Given this list of marker genes DCHS1, FAT4, RAB23, SMOC1, SVBP, PORCN, FERMT1, FLNA, PIGS, PRKG2, LBR, HOXD13, TBX3 (NCBI Gene Id 91834), FBXL3, SHOX, EIF4A3, MEGF8, PTCH1, GLI3, SRY, FGF16, GNAS, SMC3, here is a description of the gene set: Human Gene Set: HP_ABNORMAL_4TH_METACARPAL_MORPHOLOGY Abnormal 4th metacarpal morphology Any abnormality of the fourth metacarpal bone. species: Homo sapiens